The following is a description of a gene set: studied in species Homo sapiens from publication Miyara M, Yoshioka Y, Kitoh A, Shima T, Wing K, Niwa A, Parizot C, Taflin C, Heike T, Valeyre D, Mathian A, Nakahata T, Yamaguchi T, Nomura T, Ono M, Amoura Z, Gorochov G, Sakaguchi S (PMID 19464196) Gene expression profiles of subsets of CD4+ T cells according to their expression of FoxP3 and CD45RA were compared. FoxP3 is a key transcription factor for the development and function of natural CD4+ regulatory T cells (Tregs). Here we show that human FoxP3+CD4+ T cells are composed of three phenotypically and functionally distinct subpopulations: CD45RA+FoxP3low resting Tregs (rTregs) and CD45RA-FoxP3high activated Tregs (aTregs), both of which are suppressive in vitro, and cytokine-secreting CD45RA-FoxP3low non-suppressive T cells. The proportion of the three subpopulations characteristically altered in cord blood, aged individuals, and patients with immunological diseases. Terminally differentiated aTregs rapidly die while rTregs proliferate and convert into aTregs in vitro and in vivo as shown by the transfer of rTregs into NOD-scid-common gamma-chain-knockout mice and by TCR sequence-based T cell clonotype tracing in peripheral blood of normal individuals. Taken together, the dissection of FoxP3+ cells into subsets enables one to analyze Treg differentiation dynamics and interactions in normal and disease states, and to control immune responses through manipulating particular FoxP3+ subpopulations. Human Gene Set: GSE15659_NAIVE_CD4_TCELL_VS_RESTING_TREG_DN Genes down-regulated in comparison of naive CD4 T cells versus resting regulatory T cell (Treg)., and this is the list of marker genes: TNF, SCAMP5, TCEAL8, THBD, SP6, TRPM6, TLL2, ZNF644, TTC7A, ZNF200, SOX2-OT, UBL3, LINC01121, ZNF34, ZNF385D, WDR33, TIMM23B, TMEM158, ZMIZ2 (zinc finger MIZ-type containing 2), TTLL12, SPDYA (NCBI Gene Id 245711), ZSCAN29, TTL, SLC16A11, THBS2, SPACA7, TNR, SARS2, SAMSN1, RIPPLY2, SLC43A3, SLC4A2, RHOH, RGS17, TP53, ZNF44, SSR2, TP63, TMLHE, SCARF2, SLC4A11, SEMA4A, YRDC, SERPINB10, TBCCD1, ZNF131, SLC8B1, SHE, TK1, SPATA22, UBE2D1, SYN2, S1PR2, ZSCAN9, STK16, WNT9B, RASD1, SULT1B1, TMCO6, ZNF585B, RAB9A, STC2, SKI, TLCD1, TSNARE1, SCGB3A2, SLFNL1, ZNF678, ZNF579, TTC12, SEMA7A, CCN6, TGIF2LY, ZSCAN12, ST7-AS1, SETD6, TFF2, SERHL2, ZNF596, SECISBP2, VCPIP1, SEMA6A, TYSND1, TNNC1, SAP30BP, THRB, SHB, USP11, UBE4B, SLC25A2, SCO2, ZCCHC13, TMEM70, RANBP9, ZFP69B, RHBDL2, RNF19A, SNHG12, RAB35, SLC26A3 (solute carrier family 26 member 3), STARD4, TIFAB, RND2, ZNF268, SRL, RUSC1 (NCBI Gene Id 23623), TTLL13, TMCO5A, SNORA65, RAB17, SCN8A, UBE2U, WDR90, TTTY13, USP7, TNFSF12, VSTM1, TMEM125, TMEM208, RHOC, WFS1, SERPINA9, ZNRF2, SPATA12, ZNF430, ZNF530, SLC26A11, UBL7, ZNF432, SLC43A2, VASN, RTP1, SPATA2, SLC9A5, SEPTIN3, SNCA, SF3B4, TP53I13, ZSCAN26, SPCS2, TLN2, S100A16, SNAI3, RRM1, TRAK1, SHMT2, TRABD, TRIM54 (tripartite motif containing 54), SNAP91, SNHG4, TMEM139, SLC22A1, TAS2R9, TINF2, DNAAF10, ZNF665, ARHGAP42, TPMT, ZAN, ZNF28, RTP3, WARS1, SPATC1, RPL3L, SLC22A18, WDR74, YIPF2, STK32A, VEGFB, SAGE1, UTP23, WDR89, ROS1 (ROS proto-oncogene 1, receptor tyrosine kinase), RSPH10B2, ZIC1, VENTXP1, RAMP1, TOP3A, SPATS2L, TRIM36, CTNS, ENTR1, UTS2B, ZNF142, TCN2, RGPD5, RAB8B, SLC6A7, RNF113A, TPR, TLX3, TREX1, STK25, CCDC97, SGO2, ZMYND11, ZNF285, ZNF861P